Given this list of marker genes ABCA4, here is a description of the gene set: species: Homo sapiens part of: Retinoid cycle disease events Reactome Pathway: Defective visual phototransduction due to ABCA4 loss of function ATP-binding cassette protein A4 (ABCA4, ABCR), expressed exclusively in retinal photoreceptors, is thought to be involved in the clearance of toxic by-products of the retinoid cycle. Defects in ABCA4 cause a diverse range of human diseases. One such disease is Stargardt's disease type 1 (STGD1, MIM:248200), an autosomal recessive form of juvenile macular degeneration leading to progressive irreversible loss of central vision and delayed dark adaptation. STGD1 was first identified by Stargardt in 1909 (Stargardt, Arch. Klin. Exp. Ophthal. 71: 534-549, 1909), has an approximate prevalence of 1 in 10,000 (see reviews Paskowitz et al. 2006, Walia & Fishman 2009) and is usually diagnosed within the first two decades of life.